Given this list of marker genes Gas2l2, Gas2l1, Cript, Mapre2, Abhd17a, Ttbk2, Hnrnpu, Kif20b (NCBI Gene Id 286943), Champ1, Abhd17b, Map1a, Mid2, Abhd17c (abhydrolase domain containing 17C), Gsk3b, Mapre3, Mapre1, Dvl1, Mid1, Diaph1, Abl1, here is a description of the gene set: Mouse Gene Set: GOBP_PROTEIN_LOCALIZATION_TO_MICROTUBULE A process in which a protein is transported to, or maintained at, a microtubule. studied in species Mus musculus